The following is a description of a gene set: Mouse Gene Set: GOBP_REGULATION_OF_PROTEIN_LOCALIZATION_TO_CHROMATIN Any process that modulates the frequency, rate or extent of protein localization to chromatin. species: Mus musculus, and this is the list of marker genes: Vrk1, Sirt6, Vcp, Cdk9, Setd2, Spi1, Pias4 (protein inhibitor of activated STAT 4), Rnf4, Vcpip1